The following is a description of a gene set: studied in species Homo sapiens Human Gene Set: HP_ABNORMAL_FUNDUS_MORPHOLOGY Any structural abnormality of the fundus of the eye. Abnormal fundus morphology, and this is the list of marker genes: NCAPG2, FCSK, NAGA, RSPO2, SLC39A14, TMCO1, PAK2, MED12, TSFM, ARMC9, DENND5A, SH2B1, CEP41, CASZ1, CBS, CDON, STX3, SERAC1, FBXL4, TLR7, LRP5, NT5C2, PRPF8, GNAT1, XPC, LAMB1, ATXN7, TRAF3IP1, RREB1, PEX12, HMX1, ACVRL1 (NCBI Gene Id 94), CNGA3, FKBP6, SDCCAG8, SDHAF1 (NCBI Gene Id 651076), PCK1, POU3F4, WDR11, IFNG (NCBI Gene Id 3458), MGP, ACO2, RHOA, RFC2, LRRC32, COA8, SALL2, DRC1, GABBR1, PCDH15, PTCD3, POMGNT2, ATXN1, FKRP (NCBI Gene Id 79147), NDUFAF2, DNM1L, DGCR6, EXOC8, ETS1, AFG3L2, BBS12, TEK, ERCC5, LZTFL1, LDLRAP1, MKS1, KLF11, PPP3CA, MT-ND4, CYP7B1, MAB21L1, VSX1, MMP23B, BOLA3, NSMCE2, SMOC1, CFHR3, RECQL4, IL11RA, ODAD1, HUWE1, RBL2, KIF7, NEK8, COG6, GNAT2, VCAN, AARS1, PEX3, FBLN1, MTSS2, NDUFA1, GJC2, SOX3, ARSG, PIGL, BBS9, MT-TH, ZEB1 (NCBI Gene Id 6935), CNGA1, ALDH1A3 (NCBI Gene Id 90476), TANGO2, CCND1, BBIP1, MPV17, KIAA0586, NDUFS2, ERF, MAP2K2, SSBP1, AHI1, MRPS34, COX8A, IL12A-AS1, GAS2L2, DPYSL5, C19orf12, FANCB, RAB28, NDUFS6, TMEM216, MIA3, FGFR2, YWHAG, MT-TV, MT-TL1, LARGE1, STAT3, CFHR1, ACER3, PMPCB, KCNJ11, KIAA0753, LRTOMT, IDH3B, TUBB4B, APOC2, SLC44A1, OCRL, CEP164, ZEB2, METTL27, SAR1B, IL10, CABP4, C2CD3 (NCBI Gene Id 26005), PRDM16, OTX2, IDH3A, BBS7, MT-CO2, RSPH3, CCDC28B, FOXJ1, RBMX, RPGR, TRIM32, TNFRSF11B, PIGG, SH3TC2, AUH, NDUFAF1, TIMM50, PDGFB, ALG12, MPDU1, MYO6, PDE6H, FGFR1, CDH11 (cadherin 11), ASNS, CACNA1A, NDUFS3, PPP1CB, PISD, ESAM, MAPRE2, DNAI1, G6PC1, PDGFRB, DGCR8, ATIC, LIPH, MCIDAS, USP45 (ubiquitin specific peptidase 45), FIBP, CASK (calcium/calmodulin dependent serine protein kinase), RDH12, TRPM1, DYRK1A, GEMIN4, ARX, MFRP, TCIRG1, SLC25A19, NDUFA13, IMPG2, TUBA8, LIMK1, DNAH11, TLR4, POLG2, PERCC1, MFSD8, MSTO1, PHYH, ZMYND10, NEK2 (NIMA related kinase 2), MT-ATP6, HLA-DPA1, OSTM1, CDH3, TUB, SLC38A3, NMNAT1, SPATA7, SLC29A3, WWOX, CARS1, AAAS, MECR, UBA5, NDUFV1, GABRA5, TIMP3, B9D2, EXOSC2, RERE, MT-ND4L, CTSA, COL9A3 (NCBI Gene Id 1299), SIM1, IFT43, MFF, IGFBP7, PCLO, CHRDL1, ADAR, SCYL1, WT1, ACTG1, TMEM270, BLOC1S5, DLK1, IFT27, POMK, ATP6V1A, SIX6, TRAK1, HPS4, BAZ1B, MAP2K1, SLC13A5, NEU1, WDR19, EXOSC5, CASR, NDUFAF8, CFAP300, LCA5, COQ2, IFT52, TUBB3, TOE1, INVS, ATP6V1E1, MKKS, PDE6A (phosphodiesterase 6A), UBE2L3, UBE3B, EXOSC3, MSRB3, MT-TW, RDH5, GPAA1, MT-CO3, ELN, MACF1, IFT172, CYP1B1, MTRFR, DARS2, VWA8, ERCC3, NRL, AKT1, AP3D1, NR3C1, SBF2, CTNNA1, TELO2, INSR, CDHR1, TMEM63A, TBC1D7, ASXL1, ATP6V0A2, NDUFS4, PDE6C, GABRD, DPM2, TREX1, RRAGC (NCBI Gene Id 64121), VPS41, FKTN, POT1, PORCN (porcupine O-acyltransferase), GRHL2, WFS1, UBE4B, MMP2, GDF3, CLCN3, SNAP29, KDM6A, TOPORS, ADAMTS18, PIK3CA, DNASE1, SLC25A11, CRYAB, TRIM44, RNU4ATAC, CA2, ALMS1, PPP1R21, MT-TP, SLC30A9, SPTBN1, ENPP1, TMEM98, FRG1, KCNA2, MAG, CLP1, RXYLT1, RBP4, TRIM37, TRAF7, WASHC5, DGCR2, NF2, NUP54, GTF2H5, GDF6, CPLX1, DYNC2H1, DNAJC30, WAC, MAF, PCYT1A, INTS8, ABCG5, GMPPB (GDP-mannose pyrophosphorylase B), HID1, NEK10, IMPDH1, ATAD3A, SYNJ1, TAF2, TK2, PI4KA, STUB1 (STIP1 homology and U-box containing protein 1), EXOC2, KIF1A, SMCHD1, RNF170, NDUFAF3, VPS33A, NARS2, RTN4IP1, NDUFAF4, ATF6, KIF5A, HGSNAT, ODAD3, GABRA2, RSPH9, CTSD, XYLT1, GABRB2, SLC6A9, MERTK, RBP3, CYSLTR2, KAT6A, MITF, TSPAN12, ITM2B, NDUFA9 (NCBI Gene Id 4721), MORC2, POMT2, PEX16, TNFSF11, PLOD1, B3GLCT (NCBI Gene Id 145173), GLA, HEXB, ATG7, HSD11B2, DDR2, PCYT2, MTO1, TPI1, MTOR, OTUD5, WDPCP, POGZ, NR2F1, EPAS1, IGHG1, SEMA4A, NPHP4, RDH11, INPP5E, HADHA, PPP2R3C, KCNAB2, LOXL3, MT-TF, CSF1R, GUCA1B, BTD, CHM, FZR1, ZNF423, PRPF4, MEF2C, NTRK2, TEFM, CLN6, PRPF6, DPYD, TRRAP (NCBI Gene Id 8295, transformation/transcription domain associated protein), KANSL1, SYNGAP1, PANK2, CPSF3, PPT1, ABCG8, NDUFC2, APOB, FCGR2B, ASPA, ATCAY, DLST, WDR45, RAX2, SPP1, SPAG1, ACTB, GCK, GLRX5, FDX2, SEC23A, COL18A1, NSD2, FA2H, RSPH1 (NCBI Gene Id 89765), RAB23, MIEF1, PTPN22, RPE65, NME5, NUS1, KCTD7, IFT140, FBLN5, FRMPD4, FZD4, NDP, GATA2, TUBB4A, LIG3, DYNC2LI1, RAP1B, EEF1A2, RAX, ATP5F1A, ARL2, MAPKAPK3, APOE, MT-RNR1, SLC52A2, ARHGEF2, ELP4, RPL10, PDHX, SLC25A15, TNFRSF11A, FREM1, KIZ, PAX4, NUBPL, GTF2E2, PAX6, FLRT1, TUBGCP4, GATA3, SCAPER, GRID2, NDUFA11, MGMT, ELP1, STK36, TUBB, SIX3, TASP1, LYST, MID2, PDPN, SMARCE1, CASP2, DIAPH1, BBS1, ETHE1, GTF2IRD1, CFAP418, GTF2IRD2, POLR3K, TTLL5, VHL, TTC21B, ZNF668, TMEM126A, DGUOK, OPA1, ARVCF, STAMBP, TMEM218, PRPH2, KRT71, PDZD7, PIEZO2, AMACR, TMEM222, PEX11B, GDF2, CR2, CHEK2, VPS53, HLA-A, HMCN1, MMUT, NAA10, NDUFB9, PRDX1, DHDDS, SPTAN1, XPA, KATNB1, DOCK6, HCN1, RPS6KA3, ATP5F1E, FCGR3B, SDHA, DPM1, CCNQ, TCTN2, CAPN5, FDXR, TIMM8A, RRM2B, CHST14, USH1C, RNF216, PEX7, AP1S2, COL25A1, RIMS1, PLP1, MYO5A, LRIT3, XYLT2, ARL6IP6, ANK1, POC1B, VPS35L, USH2A, MICOS13, RD3, SCN8A, NADK2, CTNNA2, CLTC, NALCN, VRK1, TMEM138, ISCA2, ATXN2, HMBS, CRB1, TGFB1, CDK4, FLCN, TMTC3, ACBD5, SLC1A2, TUBA1A, MLX, SETD2, SMG8, MC1R, CLDN19 (NCBI Gene Id 30063), PRKAR1A, C9, PUS1, TRIP13, ZNF513, BCAP31, KIDINS220, TTPA, SEC31A, RHO, EIF4A2, KIAA0319L, LZTR1 (NCBI Gene Id 8216), CCR1, RET, TUBGCP6, ATRX, DYNC2I1, CCDC39, ROM1, IBA57, TACO1, JAM3, RNU7-1, CENPF, CLN3, OFD1, RIMS2, NPHP3, SLC38A8, AIFM1, OPA3, NEUROD1, EIF2B1, JAG1, PLA2G5, WHRN, PTEN, GZF1, RAB11B, CST3, CEP78, ATP5F1D, IPO8, AGTPBP1, ERCC8, LDLR, ANTXR1, ATPAF2, PGAP1, PIGU, RAB3GAP1, TERT, NR2E3, CCDC40, BEST1, BCS1L, ANKRD11 (ankyrin repeat domain containing 11), PEX5, HESX1, RSPH4A, BANK1, PEX26, MTPAP, GABRG2, ESS2, CDK19, MAN2B1, SEMA3E, INTS11, UQCRFS1, RLBP1, CFAP221, ITPR1, SERPINC1, CEP83, EYS, OVOL2, ACADS (NCBI Gene Id 35), KCNV2, EIF4H, BRAT1, PUF60, HLA-B, FAS (NCBI Gene Id 355), NDUFS8, MYO7A, HEXA, ARNT2, TTC8, SKI, BUD23, TRAPPC12, KLF1, TUBB2B, MT-CO1, ADAM22, TFAP2A, CPAMD8, DBR1, WNT3 (NCBI Gene Id 7473), COL9A2, MEG3, IRF5, MICU1, MLXIPL, GPR161, PMM2, TENM3, FGF12, HYDIN, TUBGCP2, MYD88, COL11A1, SLC45A2, TSC1, EIF2B4, CLCC1, BCOR, ALG13, ALPK1, NDUFA6, EXOSC9, GTF2I, MT-TN, SELENOI, DKC1, EBP, NPHP1, ZNF592, MT-ND3, ROBO1, PLXNA1, SCYL2, MMP14, ADAMTSL4, CLCNKB, ALG3, PLAA, GM2A, KNSTRN (NCBI Gene Id 90417), ABCB6, DCT, DYNC2I2, IER3IP1, IQSEC2, IL12A, RMRP, ITGAM, XRCC4, SCO2, HSPG2, FXN, CYFIP2, SLC19A2, CFAP410, COX7B, CREBBP, ZNHIT3, SLC35A2, LCK, SPOP, NDUFB3, FOXRED1, FOXG1, IDUA, SMO, TERF2IP, AP5Z1, CHD7, SYNE1, LMNA, SEC24C, DDX59, SPG11, CNGB1, PEX2, KCNC3, CTNS, ALDH3A2, ZNF408, B3GALT6, GLI2, JAZF1, IVNS1ABP, SMPD1, SOST, NDUFB10, GRIA4, SLC12A6, AHDC1 (AT-hook DNA binding motif containing 1), PHOX2A, BAP1, GABBR2, DNAJB13, ARL6, ESPN, ODAD2, PDSS1, CSPP1, NFU1, PDXK, TYR, TCTN1, KIF21A, PEPD, CDC42BPB, RAB18, ABHD12, SPINT2, RFX7, BRAF, TNFAIP3, DNAI2, LHX3, LRRC56, SCN3A, HK1 (hexokinase 1), NCF1, IFNGR1, FZD5, HPS5, MIR204, NUP62 (nucleoporin 62), GSN, DNM1, GPIHBP1, OPN1MW, DHX16, TMEM127, THSD1, SPEN, SLC37A4, RELN, TWIST1, ZFYVE26, DLAT (NCBI Gene Id 1737), THG1L, IQCB1, SRD5A3, DRAM2, PAX2, PRICKLE3 (NCBI Gene Id 4007), LRP4, DUX4L1, NRCAM, ALDH6A1, FGFR3, AASS, COL11A2, EMC1, ATP5MK, LHX4, PNPLA6, L2HGDH, ISCA1 (NCBI Gene Id 92236), MT-ND1, ARSL, NF1, JMJD1C, CACNA2D1, RP1, EPCAM, GNAQ, SNX10, RB1, LRAT, ASAH1, HNF4A, ODAD4, MT-ND6 (mitochondrially encoded NADH:ubiquinone oxidoreductase core subunit 6), NDUFB11, PRKCZ, CLCN2, GNPTAB, USH1G, NEFL, FLII, TLCD3B, MECP2, ARHGEF18, CEP85L, CCNO, GJA1, KLRC4, CRLS1, AP3B1, DAG1, POLG, NYX, COL4A1, B4GAT1, MTHFR, CPLANE1, FOXE3, STN1, PDE6G, PEX6, ERCC6, SLC6A6, PCSK9, CACNA2D4, MT-ND2, PIK3CD, DHCR7, SLC25A46, ELOVL4, FBXO28, TSEN54, MDH2, CFAP298, TWNK, CLN8, FLNB, PEX10, TBX1, CFH, CNNM4, PRCD, IKBKG, HARS1, NME8, OPN1SW, AGXT, GSS, GGCX, LYRM7, FOXA2, DNAH5 (NCBI Gene Id 64774), KRAS, CFI, FLVCR1, MYOC, DNAAF1, FANCI, DNMT3B, COX15, KIAA1549, MT-ATP8, TP53, PPIP5K2, SACS, VPS37D, MT-CYB, CP, SBDS, NHS, ATP1A2, CAV1, SALL1, CIB2, GUCY2D, CEL, COL9A1, IL12B, GFPT1, RNU4-2, DNAAF11, CC2D2A, TRAPPC11, GALNT3, GRM6, HADHB, HNRNPU, RNF113A, HLA-DRB1, CYP4V2, ANO10, DNAAF3, BBS10, GLB1, TXNDC15, NGLY1, MUTYH, PGK1, POLR3A, COL8A2, PXK, NLRP3, TBCE, PSAP, CKAP2L, PIBF1, TSC2, DNMT1, ALDH1A2, ATOH7, EPHA2, PCARE, SUMF1, MAN2C1, LAMA1, TRAPPC9, TINF2, ZSWIM6, YARS1, EPRS1, TARS1, UNC119, CTC1, RTTN, SDHC, DNAJC21, CEP19, FUCA1, KRT74, MAX, MEFV, OAT, DPAGT1 (dolichyl-phosphate N-acetylglucosaminephosphotransferase 1), DNM2, SPEF2, HBG2, EIF2B2, ARL3 (NCBI Gene Id 403), IFT74 (NCBI Gene Id 80173), USP48, IFT88, KRT25, HBG1, HTRA1, PRPF31, MBTPS2, BLOC1S3, GATAD2B, CNKSR2, MTTP, DNAH9, CCDC22, NBAS, TMEM107, VPS11 (VPS11 core subunit of CORVET and HOPS complexes), LETM1, ALG6, USP8, ADGRV1, SOX2, TCTN3, PDE6B, PRDM5, SCN1A, C12orf57, ATP6V1B2, HSD17B10, ERAP1, HHAT, KCNJ13, TERC, CNOT3, PEX14, PRSS56, SDHB, DDB2, HIRA, MPDZ, HBB, KCNB1, DNAAF4, CHST6, PLA2G6, IGBP1, NFIX, SPG7, SLC4A2, TULP1 (NCBI Gene Id 7287), MAK, GFM2, CHN1, MCOLN1, CTBP1, ADAMTSL1, PEX19, ACTL6B, MPLKIP, CYP27A1 (cytochrome P450 family 27 subfamily A member 1), TTC12, CTNNB1, COL2A1, MFN2, PRUNE1, RAB3GAP2, CEP120, AP3B2, MT-ND5, KCNC2 (potassium voltage-gated channel subfamily C member 2), RTL1, IMPG1, POMT1, TRPM3, GPR179, DTNBP1, SLC24A5, PTCH1, SON, FSCN2, P3H2, AGBL5, ENG, GLYCTK, CACNA1C, ZNF469, IFT80, GUCA1A, WDR4, RPGRIP1L, KIF14, IRAK1, MTFMT (mitochondrial methionyl-tRNA formyltransferase), CCDC88A, AHR, PRPS1, STT3B, PRTN3, KCNK4, TMEM237, RGR, PEX13, IFT122, PEX1, HIKESHI, POLR3B, MMP19, DNAAF5, DNA2, PROKR2, GTPBP2, PARS2, YAP1 (NCBI Gene Id 10413), DALRD3, TBC1D20, SZT2, ADAM9, AMPD2, ARL13B, TRIT1, CACNA1B, RAI1, EDNRB, CRX, COG1, LPAR6, CISD2, F12, TXN2 (thioredoxin 2), ARV1, TMEM231, KRIT1, TRAPPC2, NBN, DNAH1, NOTCH2NLC, ATP2B2, PRORP, UFD1, ZMYM3, RP2 (NCBI Gene Id 6102), CNGB3, B9D1, SP7, KMT2D, ZPR1, TNFSF4, ELMO2 (engulfment and cell motility 2), MINPP1, ASB10, MCAT, BBS2, SAG, SF3B1, FOXC1, CLN5, BBS4, BMP4, TOR1A, UGP2, PAX3, IL23R, GMPPA, AKT3, GRN, EXOSC8, PROM1, GPR143 (G protein-coupled receptor 143, NCBI Gene Id 4935), PRF1, BLM, MMACHC, DDHD2, VPS4A, LRP2, INTS1, NOTCH3, SOX5, SMARCB1, TBC1D24, RP9, DNAAF2, ERCC4, RPIA, FAM111A, PRDM10, DHX38, ARL2BP, DNMT3A, HNRNPK, SYCE1, LUZP1, ATN1, TEAD1, ZIC1, INS, AP4M1, DNAAF6, NDUFS1, ACTA2, LPL, NECAP1, ZFX, DSE, ALG8, DUX4, POU1F1 (NCBI Gene Id 5449), CDKN2A, UBAC2, PDCD10, EDN3, MRPL39, SURF1, HADH, CEP290, TYRP1, P4HTM, ARSA, ERCC2, UCHL1, GALC, NDE1, RPGRIP1, SH3BP2, PROS1, BBS5, ERCC1, DACT1, HPS1, REEP6, ABCA4, NDUFAF5, PACS2, TIMMDC1, GP1BB, MAPKAPK5, PROP1, FDFT1, TBX22, KIF1B, VPS13B, NEDD4L, TMEM126B, STX1A, MT-TK, APC, TFG, STAT4, LHFPL5, CLRN1, ABCC6, HKDC1, DARS1, ACD, MAGEL2, PTPN23, HCCS, MOGS, HACE1, IDS, RS1, ST3GAL5, DST, MVK, B3GALNT2, TMEM53, CCM2, GNA11, OPN1LW, AIPL1, P4HA2, SLC7A14, NEK1, NDUFV2, DPP6, CLCN7, DEAF1, KIF3B, SARDH, SOX10, RFC1, CHSY1, PRPF3, AFF4, CLEC3B, CERKL, CDKN2B, FH, PIGA, RBM10, PLEKHM1, HPS6, GBA1, HMGB3, PDCD1, TPP1, PRR12, WDR73, PTF1A, RNASEH1, CLIP2, PIGB, TMEM67, NOD2 (nucleotide binding oligomerization domain containing 2), WRN, GP1BA, TMEM106B, C4B, TBCD, CTLA4, POMGNT1, NELFA, PLK4, CWC27, CELF2, RNF135, KLC2, GCDH, PITPNM3, PDE6D, BCL11A, SMAD4, ATP1A3, SV2A, LOXL1, GRIN2D, RP1L1, SHH, MT-TS2, WARS2, YME1L1, C1QTNF5, DNAL1, LAMB2, DDX11, CDC42, BLK, GNPAT, SIL1, EPG5, NDUFS7, MT-TQ, CFAP74, HSPD1, NIPBL, AIRE, ELOVL1, SNF8, ABCC8 (ATP binding cassette subfamily C member 8, NCBI Gene Id 6833), POLR1A, GNB3 (NCBI Gene Id 2784), KLHL7, EFEMP1, TBC1D2B, TBL2, SDHAF2, TBX4, RCBTB1, MAFB (MAF bZIP transcription factor B), GRK1, PDX1, CLDN11, C4A, SUFU, PRMT7, ADA2, FBN1, HLA-DPB1, PCNA, SLC24A1, KIF11, SDHD, GNB5, SNRNP200, ACOX1, TNIP1, CACNA1F, SALL4, HNF1A, CRPPA, FAM161A, CDH23, APPL1, OCA2, FBN2, STAG2 (NCBI Gene Id 10735), SCLT1, PPP2R1A, DNAJC19, TRNT1, ANKH, COMT, HNRNPH1, CA4, BLOC1S6, FGF3, SAMD7 (NCBI Gene Id 344658)